The following is a description of a gene set: Human Gene Set: MIR3190_5P studied in species Homo sapiens Genes predicted to be targets of miRBase v22 microRNA hsa-miR-3190-5p in miRDB v6.0 with MirTarget v4 prediction scores > 80 (high confidence targets). from publication Chen Y, Wang X (PMID 31504780), and this is the list of marker genes: SH3TC2, TMEM230, SNX17, LAMC1, CNOT2, CLTC, HSD17B12, SYTL3, ETS1, RANBP10, NUFIP2, CD59, DDX3X, ITGA5, KCNC4, ZBTB39, AMACR, FBXO45, MDN1, PTPRB, TRAIP, PRR14L, WNT9B, ERBIN, SCD5, TCERG1, NKAIN1, ATXN1, CBY1 (NCBI Gene Id 25776), PHLDA2, UNC119B, PTPN14, UBE2V1, RABGAP1, MB21D2, DMXL2, GRIPAP1, CAPRIN1, SNTB2, ING5, LAMC2, KDM2A, ZFR2, ZSCAN29, STAMBPL1, ARIH2, DIO2, CCDC28A, PTX3, KRT80, WDR26, MAPK6, PEDS1-UBE2V1, SLC12A9, BICD1, DCAF7 (DDB1 and CUL4 associated factor 7), NLGN4Y, GRAMD1B, RSPRY1, ZNF540, SLC16A6, TMEM127, IBTK, ALKBH5, NT5DC3, WDR73, PAX6, AAK1, SIAH1, PLAU, FGF1, ANKRD60, PHAF1, SCARB2, XIRP1, HNMT, FOXP4, PRDX5, BTRC, NUDT3, MAPK10, CAMK1G, JMY, GREM2, RPS6KA3, NT5E, ME2, MARF1, SLC20A2, PRP4K, H2AZ2, IL1R1, FLOT2, ZYG11B, CFAP418, SPACA4, PMP2, MAP4K4, PASK, HSF5, NIPAL4, LUZP1, PRIMA1, LIMD1, CHST9, ZNF599, CYP4V2, RSBN1L, CCNF, IL17RD, ARHGAP29, RRAS2, SLF2, RALGAPB, ZNF704, SRP14, ARID3B, GPR161, GGT5, LOXL4, FAM193A, AREL1